The following is a description of a gene set: species: Homo sapiens Human Gene Set: GSE18281_SUBCAPSULAR_CORTICAL_REGION_VS_WHOLE_MEDULLA_THYMUS_UP Interaction of hematopoietic progenitors with the thymic stromal microenvironment induces them to proliferate, adopt the T cell fate, and asymmetrically diverge into multiple T lineages. Progenitors at various developmental stages are stratified among different regions of the thymus, implying that the corresponding microenvironments differ from one another, and provide unique sets of signals to progenitors migrating between them. The nature of these differences remains undefined. Here we use novel physical and computational approaches to characterize these stromal subregions, distinguishing gene expression in microdissected tissues from that of their lymphoid constituents. Using this approach, we comprehensively map gene expression in functionally distinct stromal microenvironments, and identify clusters of genes that define each region. Quite unexpectedly, we find that the central cortex lacks distinctive features of its own, and instead appears to function by sequestering unique microenvironments found at the cortical extremities, and modulating the relative proximity of progenitors moving between them. from publication Griffith AV, Fallahi M, Nakase H, Gosink M, Young B, Petrie HT (PMID 20064453) Genes up-regulated in thymus subcapsular cortical region versus the whole medulla., and this is the list of marker genes: PLXNB2, ADGRG1, SSBP3, WIPF2, ARHGAP28 (Rho GTPase activating protein 28), AREL1, TCF20 (transcription factor 20), PLOD1, OR1D2, BPI, TSC2 (TSC complex subunit 2), PBK, EHBP1L1, KCNH1, ADRA2B, GATA1, ANAPC2, POLA2, RUSC1, SLC2A9, NCAPG2, POMT1, ATG13, DDX27, ELK1 (ETS transcription factor ELK1), KIAA0087, C11orf24, TMEM132A, ABCB1, AAK1, EP300, PMP2, PIAS3, TTK, ADH1B, BMERB1, ZNF79, ACD, ESYT1, RPS6KB1, EPS8L2, EDEM2, TCF7L1, MED12, SRRM2, UCP1, SZT2, PSEN1, TFIP11, PNLIP, ERBB2, BRF1, MEN1, CDKN3, PPP2R5B, CA12 (carbonic anhydrase 12), CCDC51, POLR2A, NEIL3, PRKAB1, BRD4, POLR3E, ALG9, NLRP1, SIM2, OR1A2, SERPINA2, BCAM, LIMK2, ARPC4, TRIL, SDC2, NISCH, CTDSPL, EIF3B, RNF216, TEAD3, CELSR1, ITGB4, EHMT2, INHBE, HTN1, PIAS1, CNKSR1, FHIP2B, STIMATE, APLP2, PRRC2A, ZNF225, TSHB, COG2 (NCBI Gene Id 22796), CLCN7 (chloride voltage-gated channel 7), MIA3, NFIC, MADD (MAP kinase activating death domain), CBX2, SORBS3, KRT5, SCMH1, POGK, SHANK1, CHEK1, MAP3K3, LHPP, ZNF177, SUPT6H, KRT20, ZNF8, GRIP2, STMN2, JUP, LIPE, GUCA1B (NCBI Gene Id 2979), ERCC3, ATP6V0C, ATP13A2, INSR, NAT10, RRAGA, SIN3B, NEUROD6, ERC1, FAM222B, CDC25B, KRT12, DAZAP1, GJB5, DCTN1, PKN2, TLN1, OR2H2, AFF4, ZG16, CHD8, ZC3H4, CAMK1D, ARHGAP32, C6orf62, NSD1, KPNA6, FANCI, TRPC4AP, KDM1A, HDAC7, NOTCH1, DESI1, MS4A3, KLK10, NCOA1, POLR2E, DSN1, MOGS, MYD88, LUC7L, HSPG2, PIMREG, IDUA, ACIN1, GEMIN4, TYMS, MMP16, TPCN1, COL7A1, RNF39, ZYX, ANGPTL3, CPSF1, TESK1, STX5, ERG, CENPE, ZNF500, HDGF, ZNF266 (NCBI Gene Id 10781), RFX4 (NCBI Gene Id 90489, regulatory factor X4), TCOF1, BCL9, ERAL1, INTS3, BRD9, ABCF3, FAM224A, AMBRA1 (NCBI Gene Id 55626), SPG7, ADD1 (adducin 1), GM2A, LY6G6C, PNKP, MGAT1, TRRAP, MINK1, ZNF318, AGPAT1, CEP55, DKKL1, TADA3, SRSF9, GOSR2, MEPE